The following is a description of a gene set: The organization process that preserves a dendritic spine in a stable functional or structural state. A dendritic spine is a specialized protrusion from a neuronal dendrite and is involved in synaptic transmission. species: Homo sapiens Human Gene Set: GOBP_DENDRITIC_SPINE_MAINTENANCE, and this is the list of marker genes: ITPKA, PRNP, PICK1, ZMYND8, MIR30B, ZNF804A, APOE, TANC1, INSR (insulin receptor), HOMER1, INS, GRIN2B, CTTN, NEDD9 (neural precursor cell expressed, developmentally down-regulated 9), ABHD17B, FYN, CFL1, IGF1R, VPS35, APP, FCGR2B, TREM2, ITGA3 (NCBI Gene Id 4454), MTMR2